The following is a description of a gene set: Down-regulated genes in A2780 cells (ovarian cancer) treated with 17AAG, a chemical with anticancer properties. The promising antitumor activity of 17-allylamino-17-demethoxygeldanamycin (17AAG) results from inhibition of the molecular chaperone heat shock protein 90 (HSP90) and subsequent degradation of multiple oncogenic client proteins. Gene expression microarray and proteomic analysis were used to profile molecular changes in the A2780 human ovarian cancer cell line treated with 17AAG. Comparison of results with an inactive analogue and an alternative HSP90 inhibitor radicicol indicated that increased expression of HSP72, HSC70, HSP27, HSP47, and HSP90beta at the mRNA level were on-target effects of 17AAG. HSP27 protein levels were increased in tumor biopsies following treatment of patients with 17AAG. A group of MYC-regulated mRNAs was decreased by 17AAG. Of particular interest and novelty were changes in expression of chromatin-associated proteins. Expression of the heterochromatin protein 1 was increased, and expression of the histone acetyltransferase 1 and the histone arginine methyltransferase PRMT5 was decreased by 17AAG. PRMT5 was shown to be a novel HSP90-binding partner and potential client protein. Cellular protein acetylation was reduced by 17AAG, which was shown to have an antagonistic interaction on cell proliferation with the histone deacetylase inhibitor trichostatin A. This mRNA and protein expression analysis has provided new insights into the complex molecular pharmacology of 17AAG and suggested new genes and proteins that may be involved in response to the drug or be potential biomarkers of drug action. studied in species Homo sapiens from publication Maloney A, Clarke PA, Naaby-Hansen S, Stein R, Koopman JO, Akpan A, Yang A, Zvelebil M, Cramer R, Stimson L, Aherne W, Banerji U, Judson I, Sharp S, Powers M, deBilly E, Salmons J, Walton M, Burlingame A, Waterfield M, Workman P (PMID 17409432) Human Gene Set: MALONEY_RESPONSE_TO_17AAG_DN, and this is the list of marker genes: CYCS, ABCE1, ILF2, HNRNPA1, LDHA, SEC62, RPS16, IARS1, CCT6A, POLR2L, PTGES3, GJA1, SYNPO, NACA, PSMA5, ELOB, CALM2, CLTA, ZNF43, XRCC5, SRSF2, SUB1, UBE2C, TIMM23, PLK1 (NCBI Gene Id 5347), DYNLL1, RPL35, ARF4, TMSB4X, RSU1, RBMX, SYK, PRDX4, SNCA, KPNA2, MAD2L1, RPL30, GM2A, SNRPB, MARCHF6, H4C3, HNRNPAB, HNRNPM, SRSF7, SRSF3, GTF2A2, VDAC3, MDH1, SNRPF, GNPAT, CLDN3, RPS8, PSMA7, WRN, HAT1, ATP5F1C, RPL27A, PRDX3, SMAD5, YWHAE, PDCD5, PA2G4, RRM2, ABCD3, SNRPE, EIF4A1, BABAM2, SSB, CLTB, RPL36AL, PTMA, SNRPG, CA12, ATP5ME, MAMDC2, GNG10, TPI1